Given this list of marker genes Pgm2, Ada, Tk1, Dtymk, Nt5e, Aprt, Ak1, Dctd, Mtap, Adk, Dnph1, Qng1, Hprt1, Pnp, Adal, here is a description of the gene set: studied in species Mus musculus Mouse Gene Set: GOBP_NUCLEOBASE_CONTAINING_SMALL_MOLECULE_BIOSYNTHETIC_PROCESS The chemical reactions and pathways resulting in the formation of a nucleobase-containing small molecule: a nucleobase, a nucleoside, or a nucleotide.